Given this list of marker genes TACSTD2, SLC26A5, FZD3, SNTA1, NKD2, DVL1, EPCAM, MYO1A, SLC6A9, SLC22A1, CLDN1, BVES, ATP6V1B1, CLDN4, DVL2, ANK3, GPSM2, CEACAM1, SLC16A1, DMD, CORO1C, KCNB1, MARK2 (microtubule affinity regulating kinase 2), AKAP7, SLC16A3, TBCD, ERBB3, MTCL1, DLG1, CDH1, CLDN5, CLDN15, ATP1B2, DSG1, MYO1C, SLC26A7, DSG2, CLDN12, ABCC1, NUMA1, ARL2, SCN5A, PKD1, IQGAP3, CLDN3, NSG1, CLDN18, DRD2, MPP7, RAB13, CTNNB1, C1QTNF5, AXIN1, ATP1A1 (NCBI Gene Id 476), ANXA1, PTPRO, PPP2R1A, ATP1B1, VANGL1, IQGAP1, FGF13, CLDN7, APC, VANGL2, SLC12A2, GNA12, here is a description of the gene set: Human Gene Set: GOCC_LATERAL_PLASMA_MEMBRANE The portion of the plasma membrane at the lateral side of the cell. In epithelial cells, lateral plasma membranes are on the sides of cells which lie at the interface of adjacent cells. species: Homo sapiens